Given this list of marker genes MIR141, FUCA2, HLA-DRB1, TMPRSS2, HS3ST5, FBLN1, FURIN, MIR30C1, CXCL8, BSG, TRIM5, TRIM25, LGALS9, MIR130A, ITGAV (integrin subunit alpha V), TRIM38, LGALS1 (galectin 1), LTF, TRIM21, KRT6A, BST2, BPIFA1, CAV1 (NCBI Gene Id 857), TMPRSS4, EXOC2, CH25H, ARG1, TRIM62, POMC, F2RL1, NECTIN2, SMPD1, P4HB, FMR1, CXCL6, CD4, EXOC7, PPARA, TRIM11, CD74, HMGB1, TRIM15, here is a description of the gene set: Human Gene Set: GOBP_REGULATION_OF_BIOLOGICAL_PROCESS_INVOLVED_IN_SYMBIOTIC_INTERACTION Any process that modulates the frequency, rate or extent of symbiosis, an interaction between two organisms living together in more or less intimate association. studied in species Homo sapiens